Given this list of marker genes Apol9a, Igll1, Ambp, Apol8 (NCBI Gene Id 239552), Apol7b, Apol11b, Hbb-bt, Apoa1, Alb, Apol7e, Apol10a, Apol7a, Lrp1, Hpx, Apol10b, Cd163, Apol9b, Hp, here is a description of the gene set: This event has been computationally inferred from an event that has been demonstrated in another species.<p>The inference is based on the homology mapping from PANTHER. Briefly, reactions for which all involved PhysicalEntities (in input, output and catalyst) have a mapped orthologue/paralogue (for complexes at least 75% of components must have a mapping) are inferred to the other species. studied in species Mus musculus part of: Binding and Uptake of Ligands by Scavenger Receptors electronically inferred by orthology from the curated human pathway Reactome Pathway: Scavenging of heme from plasma